The following is a description of a gene set: Any process that stops, prevents or reduces the frequency, rate or extent of tumor necrosis factor superfamily cytokine production. species: Homo sapiens Human Gene Set: GOBP_NEGATIVE_REGULATION_OF_TUMOR_NECROSIS_FACTOR_SUPERFAMILY_CYTOKINE_PRODUCTION, and this is the list of marker genes: LTF, LILRA4, NR1H4, TREM2, GHSR, FXR1, CHRNA7, HSF1, CACTIN, ELF4, MIR130A, ARRB2, SLAMF1, IGF1 (NCBI Gene Id 3479), AXL, CD33, SYT11, TLR4, THBS1, PTPN6, ACP5, MIR204, DICER1, TWIST1, MIR140, LILRB1, BCL3, AKAP8, IL37, MIR920, POMC, CX3CL1, SIRPA, SELENOS, MIR181A2, MIR125B1, LILRB4, GSTP1, NFKBIL1, ERRFI1, MIR708, ADIPOQ, VSIR, MIR185, MIR132, FOXP3, C5AR2, IRAK3, ARG2, ILRUN, CIDEA, MIR488, TRIM27, GAS6, TNFAIP3, ZC3H12A, MIR101-1, CD274, RARA (NCBI Gene Id 5914), CLEC4A, GHRL, TLR6, HDAC3, LBP, MIR195, MC1R, ORM1, GPR18, MIR6869, LGALS9, MIR98, DEFB114, BPI, MIR149, HAVCR2, IL10, IL4, NLRC3, PTPN22, IL27RA, GPNMB, TSPO, MIR105-1, RAD21